Given this list of marker genes Ppa2, here is a description of the gene set: Reactome Pathway: Mitochondrial tRNA aminoacylation This event has been computationally inferred from an event that has been demonstrated in another species.<p>The inference is based on the homology mapping from PANTHER. Briefly, reactions for which all involved PhysicalEntities (in input, output and catalyst) have a mapped orthologue/paralogue (for complexes at least 75% of components must have a mapping) are inferred to the other species. part of: tRNA Aminoacylation electronically inferred by orthology from the curated human pathway studied in species Mus musculus